Given this list of marker genes MAPT (microtubule associated protein tau), PTPN22, AP1G1, TNFRSF1A, NLRP3, FAS, SHMT2, here is a description of the gene set: Dilatation of the blood vessels of the conjunctiva leading to a red appearance of the sclera. studied in species Homo sapiens Human Gene Set: HP_CONJUNCTIVAL_HYPEREMIA Conjunctival hyperemia